Given this list of marker genes Rdh9, Rdh1, Rdh19, Rdh10, Prmt3, Rdh16f2, Rdh16, Akr1c18, here is a description of the gene set: Mouse Gene Set: GOBP_REGULATION_OF_RETINOIC_ACID_BIOSYNTHETIC_PROCESS studied in species Mus musculus Any process that modulates the frequency, rate or extent of retinoic acid biosynthetic process.